Given this list of marker genes ERGIC3, DPT, KLHL22, STEEP1, CDC26, SVBP, ALCAM, UBL7 (ubiquitin like 7), AP1M1, CIPC, MEF2B, FBXO32, PKD1, CBLN1 (NCBI Gene Id 869), UTP3, PLEKHS1, CPT1A, IL2RA, GBP2, ITM2C, PLXND1, GPR65 (NCBI Gene Id 8477), ARL4D, TREX1, MNS1, FANCA, ZNF354C, MDM2, SLC6A4, NR4A3, UCHL3, PPP6R2, DYNLT2, RNF135, LRRC8A, CA13, KDM5B, KGD4, ZFP30, AGAP2, HIGD1C, EPHX1, SDCBP2, TIMP1, ANXA4, ITPA, ZBP1, CD86, ZUP1, ASPRV1, CCNA1, NUFIP1, PACRGL, ECE1, THAP4, AOC3, IFIT3, RBM28, IL1RN, CCL17, ADARB2, PPIL2, DENND4B, CIITA, ADPRM, ASB11, ZC3H14, NR4A2, RNF34, AKR1B1, SLC12A9, GYPC, GRIA3, COQ8A, EFNB2, PSME2 (proteasome activator subunit 2), CFAP141, SAT1, NBN, FABP4, CDH9, LDHA, RCOR3, PTCH1, PTPRT, CEP19, GALNT10, PNPLA7, OSER1, PRPF38A, SLC37A2, TNK1, HSD3B7, IL4I1, PTGES, OMA1, MTMR14, F10, MRPS6, ANAPC5, ATP5F1D, CD247, SLFN12, THAP7, SCN3A, UQCRC2, IL7R, MMP24, NDUFS3, CCDC9, CEP152, ASB13, MIF, ARHGAP20 (NCBI Gene Id 57569), HYOU1, CYTH2, CTNNB1, AVL9, HOOK2, COA3, MX1, USP19, CDC42EP4, CD80 (NCBI Gene Id 941), HEPACAM2, BRD4 (NCBI Gene Id 90616), MBD3L1, C1QL3, PIM1, SLFN13, DDX54, TAT, IER5, LRRK2, BMI1, WNT3A, PFKP, USB1, HTATIP2, NT5C3A, DGKA (diacylglycerol kinase alpha), PSMB3, ACY3, PARP8, TFAP2A, TUBB2A, TOX4, TRPM1, RGCC, NCF1, PMVK, F7, SAMSN1, IMPACT, GPR89B, MTHFR, UBE2J2 (ubiquitin conjugating enzyme E2 J2), TMEM39A, RGS1, HRH1, ACAA2, EIF1B, GFER, MX2, PNPT1, MAU2, KCNQ2, CD1D, RALBP1, NDP, THBS4, HACD4, ENO2, PDE10A, VWF, TMEM192, RNF114, SGK1, FOXC2, CASP4, KLHDC3, PARP3, TP63, TNRC18, ERCC3, KIF3A, COX6B1, GPSM1, TMA16, UQCRFS1, C1orf174, OXT, TNFSF9, IFIH1, PTPRA, FNTB, BST2, UBXN10, PTCD1, here is a description of the gene set: species: Homo sapiens Human Gene Set: GSE17721_LPS_VS_GARDIQUIMOD_24H_BMDC_UP mouse primary BMDCs were stimulated with tlr ligands and gene expression changes were profiled on Affymetrix arrays Genes up-regulated in comparison of dendritic cells (DC) stimulated with LPS (TLR4 agonist) at 24 h versus DC cells stimulated with Gardiquimod (TLR7 agonist) at 24 h. from publication Amit I, Garber M, Chevrier N, Leite AP, Donner Y, Eisenhaure T, Guttman M, Grenier JK, Li W, Zuk O, Schubert LA, Birditt B, Shay T, Goren A, Zhang X, Smith Z, Deering R, McDonald RC, Cabili M, Bernstein BE, Rinn JL, Meissner A, Root DE, Hacohen N, Regev A (PMID 19729616)